The following is a description of a gene set: studied in species Homo sapiens Human Gene Set: HP_EXCESSIVE_WRINKLING_OF_PALMAR_SKIN Excessive wrinkling of palmar skin, and this is the list of marker genes: TGM5, FGFR2, RIT1, PLOD1, CSTA, FGFR3, LZTR1, C1R, MRAS, ATP6V0A2, TBL1XR1, ZNF469